Given this list of marker genes CAV1, GRK2, NOS3, ADRA1A (NCBI Gene Id 148, adrenoceptor alpha 1A), EDN2, ADRB1, here is a description of the gene set: studied in species Homo sapiens The regulation of the force of heart muscle contraction mediated by chemical signaling, hormonal, autocrine or paracrine. Human Gene Set: GOBP_REGULATION_OF_THE_FORCE_OF_HEART_CONTRACTION_BY_CHEMICAL_SIGNAL